The following is a description of a gene set: studied in species Mus musculus Mouse Gene Set: GOBP_ONCOGENE_INDUCED_CELL_SENESCENCE A cellular senescence process associated with the dismantling of a cell as a response to oncogenic stress, such as the activation of the Ras oncogenic family., and this is the list of marker genes: Spi1, Hmga2, Pml, Cdkn1a, Hmga1b, Hmga1, Cdkn2a, Hras (NCBI Gene Id 15461)